The following is a description of a gene set: Human Gene Set: HP_ANKYLOBLEPHARON Ankyloblepharon Partial fusion of the upper and lower eyelid margins by single or multiple bands of tissue. studied in species Homo sapiens, and this is the list of marker genes: ERCC5, RIPK4, FREM2, XPC, ERCC4, TP63, BCOR, DDB2, NAA10, XPA, ERCC3, ERCC2, RAX, CILK1, IRF6, CHUK